The following is a description of a gene set: Human Gene Set: MIR6839_5P species: Homo sapiens Genes predicted to be targets of miRBase v22 microRNA hsa-miR-6839-5p in miRDB v6.0 with MirTarget v4 prediction scores > 80 (high confidence targets). from publication Chen Y, Wang X (PMID 31504780), and this is the list of marker genes: COLGALT2, FABP2, CD164, ONECUT2, TMEM70, ANKRD33B, UNC5C, WASF3, SYTL5, MID1IP1, CYB5R2, TRABD2B, MYOC, ARHGAP28, GCOM1, RUVBL1 (NCBI Gene Id 8607), ZMYND8, TDG, STAG2, FBXL17, IFT70A, KCNIP4, TMEM135, RBL2, FEZF2, MAP3K3, FBXW10B, PGRMC1, SMAD4, CT47B1, CREBBP, CAST, TMEM199, PALS1, MMD2 (monocyte to macrophage differentiation associated 2), GPATCH11, GALNT4, ZNF664, MAPK6, GPR107, MYB, RAB27A, SYF2, GALNT15, CTDSPL, NPM1, SAMD12, TCF4, DNAJA2, DACT1, RBFOX1, ABITRAM, TMEM176B (transmembrane protein 176B), SFT2D3, TMX4, ZNF534, TMEM255A, FRG2, NEGR1, BTC, MARCHF6, OTUD1, GIPC3, STN1, CDK6, TK2, EPCAM, KCNA1, AZIN1, CD1E, EMC7, CCNE2, FER, ARFGEF3, UPF3B, NCK1, SDHA, OSTC, VEGFA, DYNC1LI2, BICD2, FUT1, PLS1, NAA25, MAP3K20, APOLD1, POC1B-GALNT4, WDR26, PCDH11Y, CAND1, RAB11FIP2, C1RL, USP6NL, DBN1, CERKL, SMPD3, GUCA1C, DNMT3A, ZBTB41, FKTN, PCDH11X, USP14, ESRRG, SLC26A9, UNC5B, RASAL2, HMGN1